Given this list of marker genes Slc26a10, Sqstm1, Adamts3, Herpud1, Kcng1, Depdc1a, Xkr8, Gpatch2, Aox1, Sec23ip, Bcorl1, Syn3, Cimap1b, Slc35f1, here is a description of the gene set: from publication Chen Y, Wang X (PMID 31504780) species: Mus musculus Mouse Gene Set: MIR_6978_3P Genes predicted to be targets of miRBase v22 microRNA mmu_miR_6978_3p in miRDB v6.0 with MirTarget v4 prediction scores > 80 (high confidence targets).